Given this list of marker genes RUNX3, CR2, MYC, SNW1, HES1, RBPJ, FCER2, here is a description of the gene set: Human Gene Set: KEGG_MEDICUS_PATHOGEN_EBV_EBNA2_TO_RBP_JK_MEDIATED_TRANSCRIPTION Pathway Definition from KEGG: EBNA2 == SNW1 -> RBPJ => (LMP1,CR2,HES1,FCER2,RUNX3,MYC) EBV EBNA2 to RBP-Jk-mediated transcription. Pathway ID: N00225. Pathway type: Pathogen. Pathway class: nt06165 Epstein-Barr virus (EBV). species: Homo sapiens